The following is a description of a gene set: Learning to anticipate future events on the basis of past experience with the consequences of one's own behavior. species: Mus musculus Mouse Gene Set: GOBP_OPERANT_CONDITIONING, and this is the list of marker genes: Aldh1a7, Pde8b, Tacr1, Tacr2, Agt, Drd1